Given this list of marker genes Map2k4, Map2k7, Map3k7, Braf, Map2k2, Pak3, Pbk, Map3k1 (mitogen-activated protein kinase kinase kinase 1), Map2k5, Sbk2, Map2k1, Map2k3, Map2k6, here is a description of the gene set: studied in species Mus musculus Mouse Gene Set: GOMF_MAP_KINASE_KINASE_ACTIVITY Catalysis of the concomitant phosphorylation of threonine (T) and tyrosine (Y) residues in a T-X-Y motif in the activation loop of a MAP kinase (MAPK) substrate.